Given this list of marker genes PLK2, BLVRB, BCL2L1, LHX2, FSTL1, KIAA1671, CPM, EGFL6 (NCBI Gene Id 25975), CNN3, here is a description of the gene set: Multiple myeloma is an incurable plasma cell malignancy for which existing animal models are limited. We have previously shown that the targeted expression of the transgenes c-Myc and Bcl-X(L) in murine plasma cells produces malignancy that displays features of human myeloma, such as localization of tumor cells to the bone marrow and lytic bone lesions. We have isolated and characterized in vitro cultures and adoptive transfers of tumors from Bcl-xl/Myc transgenic mice. Tumors have a plasmablastic morphology and variable expression of CD138, CD45, CD38, and CD19. Spectral karyotyping analysis of metaphase chromosomes from primary tumor cell cultures shows that the Bcl-xl/Myc tumors contain a variety of chromosomal abnormalities, including trisomies, translocations, and deletions. The most frequently aberrant chromosomes are 12 and 16. Three sites for recurring translocations were also identified on chromosomes 4D, 12F, and 16C. Gene expression profiling was used to identify differences in gene expression between tumor cells and normal plasma cells (NPC) and to cluster the tumors into two groups (tumor groups C and D), with distinct gene expression profiles. Four hundred and ninety-five genes were significantly different between both tumor groups and NPCs, whereas genes were uniquely different from NPCs in tumor group C and genes were uniquely different from NPCs in tumor group D. Similar to human myeloma, the cyclin D genes are differentially dysregulated in the mouse tumor groups. These data suggest the Bcl-xl/Myc tumors are similar to a subset of plasmablastic human myelomas and provide insight into the specific genes and pathways underlying the human disease. Top down-regulated genes from principal component 1 (PCA1) which captures variation between normal plasma cells and tumors arising from aberrant expression of BCL2L1 and MYC. Human Gene Set: BOYLAN_MULTIPLE_MYELOMA_PCA1_DN studied in species Mus musculus from publication Boylan KL, Gosse MA, Staggs SE, Janz S, Grindle S, Kansas GS, Van Ness BG (PMID 17483317)